The following is a description of a gene set: An endocytosis process in which cell surface receptors ensure specificity of transport. A specific receptor on the cell surface binds tightly to the extracellular macromolecule (the ligand) that it recognizes; the plasma-membrane region containing the receptor-ligand complex then undergoes endocytosis, forming a transport vesicle containing the receptor-ligand complex and excluding most other plasma-membrane proteins. Receptor-mediated endocytosis generally occurs via clathrin-coated pits and vesicles. studied in species Homo sapiens Human Gene Set: GOBP_RECEPTOR_MEDIATED_ENDOCYTOSIS, and this is the list of marker genes: EFNB2, UNC119, GPR107, H1-1, FOLR1, MIR27B, LPAR1, MICALL1, RSPO1, CALY, APOC3, B2M, TAMALIN (trafficking regulator and scaffold protein tamalin), CALCRL, STON1, CAV2, GSG1L, VAC14, NRG1, CD14, IGF2R (NCBI Gene Id 3482), GTF2H2, APLNR, ATAD1, CLTB, CLN3, TPCN2, SNX17 (sorting nexin 17), CTTN, SCRIB, WASF1, PDLIM7, ARC, BICD1, FLOT1, SUSD4, SNCA, TF, FCMR, MTMR2, DRD3, MARCO (NCBI Gene Id 8685), CUBN, CEACAM1, ARF6, GRK3, ARR3, SNX1, AMN, CXCL16, STON2, LYVE1, FCGR2B, SNAP91, FCHO2, RAMP1, MIR199A1, LRP1, ARF1, DLL1, CD36, ITSN1, NCDN, CXCR1, APOC1, STAB1, DMBT1, DNAJC6, GRIA1, SDC1, RALBP1, USH1G, MSR1, RNASEK, SYK, SH3GL2, SLC9B2, CXCL8, AP2B1, FNBP1L, EZR, RABGEF1, PICALM, CCL21, VEGFA, DLG4, ITGB3, ADIPOQ, ITGAM, AP1S1, AP2A2, CAP1, AP2S1, FCER2, HAMP, AP2M1, MIR185, DKK1, RALA, SAG, LILRB4, ADM, DTNBP1, FCGR1A, LRRTM1, ACE2, TNK2, FCER1G, PROM2, SELE, ACKR3, RAMP2, SERPINE1, RAMP3, GREM1, INSR, RAB21, EPS15, OPHN1, AP3M1, NUMB, HSPG2, PCSK9, ADRB2, RAB5A, GAK, CLTC, SFTPD, FMR1, GRK2, HFE, CCR7, RAB9A, PLCG2, ENTREP1, MX2, NECAB2, USP46, LRP2, ITCH, CD81, CLTA, CAV3, SGIP1, NLGN3, ARHGAP27, HPCA, TFR2, MIR92B, RAC1, PLD2, INPP5F, SCARB2, CTSL, C3, ACHE, NEDD4L, BMP2K, CD9, ADRB3, LRP3, M6PR, SH3GL3, RAB15, ANKRD13D, SORL1, AHI1, LMBRD1, SCYL2 (SCY1 like pseudokinase 2), DRD4, HIP1, SNX9, ATXN2, ANXA2P2, APP, IL4, RABEP1, RABEPK (NCBI Gene Id 10244), MIR205, APELA, SDCBP, PIK3CB, FPR2, PLA2R1, AP2A1, TMEM108, GRB2, SMAP1, GHR, APLN, NEDD4, IGHE, MX1, DNM3, RAB31, DNM1, CLU, CD63, CBLB, CANX, GAS7, CALCA, LDLRAP1, APOE (NCBI Gene Id 99), PPT1, TFRC, ARRB1 (NCBI Gene Id 408), KIAA0319L, EGF, CLTCL1, LMBR1L, ARAP1, LRP1B, ASGR1 (NCBI Gene Id 432), RIN3, SFRP4, ANXA2, ARRB2, NTF3, DPP4, WASL, UBQLN2, PLXNB2, HIP1R, APOC2, LDLR, SCARF1, VLDLR, LDLRAD3, GH1, PIP5K1C, STAB2, CLEC4M, CLEC9A, CCL19, LRRTM2, HGS (NCBI Gene Id 9146), PPP3R1, ANKRD13A, DNAJC13, PICK1, GRK4, SIGLEC1, MIR17, CNTN2, MRC1, ITGA4, ITGB2, USP6, CCDC32, RALB, ANKRD13B, RNF220 (ring finger protein 220), FCHO1, MKLN1, FCHSD2, SYT17, NEU3, CXCR2, ABCA2, DGKD, WNT3A, LRPAP1, TBC1D5, ANGPT1, VTN, ITGB1, PIKFYVE, MDM2, CAV1, WDR54, DRD2, AAK1, HMMR, DNM2, CBL, MAGI2 (membrane associated guanylate kinase, WW and PDZ domain containing 2), RAB9B, DAB2, PI4KB, LILRB1, APOA5, ITSN2